Given this list of marker genes MOGAT2, DGAT2, DAGLA, DAGLB, PLA2G4A, DGAT2L6, DGAT1, AWAT2, MOGAT3 (NCBI Gene Id 346606), here is a description of the gene set: The chemical reactions and pathways resulting in the formation of monoacylglycerol, any ester of glycerol in which any one of its hydroxyl groups has been acylated with a fatty acid, the other being non-esterified. Human Gene Set: GOBP_MONOACYLGLYCEROL_BIOSYNTHETIC_PROCESS species: Homo sapiens